Given this list of marker genes CHEK2, MSH6, SEMA4A, MSH2, MLH1 (NCBI Gene Id 4292), BMPR1A, TGFBR2, POLD1, PMS1, POLE, CDKN2A, MDM2, ATM, RPS20, PMS2, EPCAM, ERBB2, KRAS, IDH1, BRCA2, PIK3CA, TP53, APC, MUTYH, here is a description of the gene set: Glioblastoma multiforme studied in species Homo sapiens Human Gene Set: HP_GLIOBLASTOMA_MULTIFORME A tumor arising from glia in the central nervous system with macroscopic regions of necrosis and hemorrhage. Microscopically, glioblastoma multiforme is characterized by regions of pseudopalisading necrosis, pleomorphic nuclei and cells, and microvascular proliferation.